The following is a description of a gene set: Human Gene Set: GOBP_PHOSPHATIDYLSERINE_METABOLIC_PROCESS The chemical reactions and pathways involving phosphatidylserines, any of a class of glycerophospholipids in which the phosphatidyl group is esterified to the hydroxyl group of L-serine. They are important constituents of cell membranes. studied in species Homo sapiens, and this is the list of marker genes: PLA2G15, ABHD16A, MFSD2A, PLA2G3, PTDSS2, PLA1A, PLA2G10, LPCAT3, ABHD12B, LPCAT4, ABHD16B, SERINC5, PLSCR1, MBOAT2 (membrane bound O-acyltransferase domain containing 2), OSBPL8, SERINC2, SERINC1, OSBPL10, ABHD12, MBOAT1, PLA2G2F, PTDSS1, OSBPL5